Given this list of marker genes mt-Nd3, Antkmt (NCBI Gene Id 214917), Ndufb4, Cox11, Aldoa, Impdh2-ps, Ndufa5, Ndufa8, Cmpk2, Ndufs8, Nme4, Ndufb8, Eno1b, mt-Nd4, Atp6-ps, Ndufv3, Dnajc30, Impdh1, Ndufab1, Dtymk, Sdhd, Ndufa11, Impdh2, Atp5pf, Ndufa6, Ndufs3, Ndufv1, Ndufs1, Ndufa9, mt-Atp8, Nme3, Nudt2, Atp5f1a, Ndufa1, Ppara, Sphk2, Adcy10, Ak4, mt-Nd5, Cad, Slc25a13, mt-Nd2, Tgfb1, Parp1, Ndufc1, Sdhb, Ndufb6, Tbpl1, Atp5me (ATP synthase membrane subunit e), Nme5, Ndufs4, Stat3, Eno1, Ndufs2, mt-Nd4l, Ndufa13, Lipa (NCBI Gene Id 16889), Letmd1, Nme7, Atp6v1a, Uqcc3, Atp5po (ATP synthase peripheral stalk subunit OSCP), Ndufs5, Atp5mf, Ndufb11, Ndufa7, Tmsb4x, Ndufa12, Ldhd, Ndufb3, Atpsckmt, Ndufb2, Pnp, Il4, Stoml2, Nme2, Atp5f1e, Atp5if1, Ctps1, Fam3a, Ctps2, mt-Nd6, Uck1, Uck2, Tyms, Sdha, Ak3, Ndufs7, Ldhc, Trem2, Hnf1a, Myc, Prkn, Ndufc2, Sdhc, Ndufs6, Atp5mc3, Bcl2l1, Atp5mg, Vcp, Ndufb10, Entpd1, Dmac2l, Ndufb9, Ndufa3, Nme6, Nme1, mt-Atp6, Atp5f1d, Atp5f1b, Ndufa10, Ndufa2 (NCBI Gene Id 17991), Atp5mc1, Atp5pd, Atg5lrt, Ndufb7, Ndufb5, Atp5f1c, Pid1, mt-Nd1, Ndufb1, Adk, Map2k1, Ak1, Atp5pb, Slc25a12, Atp5mc2, Ndufv2, here is a description of the gene set: The chemical reactions and pathways resulting in the formation of a nucleoside triphosphate, a compound consisting of a nucleobase linked to a deoxyribose or ribose sugar esterified with triphosphate on the sugar. Mouse Gene Set: GOBP_NUCLEOSIDE_TRIPHOSPHATE_BIOSYNTHETIC_PROCESS species: Mus musculus